The following is a description of a gene set: from publication Schaeffer EM, Marchionni L, Huang Z, Simons B, Blackman A, Yu W, Parmigiani G, Berman DM (PMID 18794802) Early prostate development genes (down-regulated at 12 hr dihydrotestosterone) which are also down-regulated in high grade prostatic intraepithelial neoplasia (PIN) vs invasive cancer. Human Gene Set: SCHAEFFER_PROSTATE_DEVELOPMENT_AND_CANCER_BOX5_DN studied in species Mus musculus Cancer cells differentiate along specific lineages that largely determine their clinical and biologic behavior. Distinct cancer phenotypes from different cells and organs likely result from unique gene expression repertoires established in the embryo and maintained after malignant transformation. We used comprehensive gene expression analysis to examine this concept in the prostate, an organ with a tractable developmental program and a high propensity for cancer. We focused on gene expression in the murine prostate rudiment at three time points during the first 48 h of exposure to androgen, which initiates proliferation and invasion of prostate epithelial buds into surrounding urogenital sinus mesenchyme. Here, we show that androgen exposure regulates genes previously implicated in prostate carcinogenesis comprising pathways for the phosphatase and tensin homolog (PTEN), fibroblast growth factor (FGF)/mitogen-activated protein kinase (MAPK), and Wnt signaling along with cellular programs regulating such 'hallmarks' of cancer as angiogenesis, apoptosis, migration and proliferation. We found statistically significant evidence for novel androgen-induced gene regulation events that establish and/or maintain prostate cell fate. These include modulation of gene expression through microRNAs, expression of specific transcription factors, and regulation of their predicted targets. By querying public gene expression databases from other tissues, we found that rather than generally characterizing androgen exposure or epithelial budding, the early prostate development program more closely resembles the program for human prostate cancer. Most importantly, early androgen-regulated genes and functional themes associated with prostate development were highly enriched in contrasts between increasingly lethal forms of prostate cancer, confirming a 'reactivation' of embryonic pathways for proliferation and invasion in prostate cancer progression. Among the genes with the most significant links to the development and cancer, we highlight coordinate induction of the transcription factor Sox9 and suppression of the proapoptotic phospholipid-binding protein Annexin A1 that link early prostate development to early prostate carcinogenesis. These results credential early prostate development as a reliable and valid model system for the investigation of genes and pathways that drive prostate cancer., and this is the list of marker genes: TUBB4A, SOX9, TMEM45A, LGALS3, TSPAN8, CAST, TLE1, MED4